The following is a description of a gene set: Human Gene Set: REACTOME_ACTIVATION_OF_THE_AP_1_FAMILY_OF_TRANSCRIPTION_FACTORS Activation of the AP-1 family of transcription factors species: Homo sapiens, and this is the list of marker genes: MAPK11, FOS, MAPK14, MAPK10, MAPK8, MAPK3, MAPK9, JUN, MAPK1, ATF2